Given this list of marker genes ANK1, NRP1, ITGA2, ITGA1, CHL1 (cell adhesion molecule L1 like), CNTN6 (contactin 6), ITGA10, ITGB1, HSPA8, here is a description of the gene set: part of: L1CAM interactions species: Homo sapiens Close homolog of L1 (CHL1) is a member of the L1 family of cell adhesion molecules expressed by subpopulations of neurons and glia in the central and peripheral nervous system. CHL1 like L1 promotes neuron survival and neurite outgrowth. CHL1 shares the basic structural arrangement of L1 family members yet in contrast to all the members it is not capable of forming homophilic adhesion. The second Ig-like domain of CHL1 contains the integrin interaction motif RGD rather than with in the sixth Ig-like domain as in L1, however the sixth Ig-like domain of CHL1 has another potential integrin binding motif DGEA. CHL1 binds NP-1 via the Ig1 sequence FASNRL to mdediate repulsive axon guidance to Sema3A. CHL1 is the only L1 family member with an altered sequence (FIGAY) in the ankyrin-binding domain, and it lacks the sorting/endocytosis RSLE motif, which is characteristic of other L1 family members. Reactome Pathway: CHL1 interactions